The following is a description of a gene set: Human Gene Set: HP_CALVARIAL_OSTEOSCLEROSIS species: Homo sapiens An increase in bone density affecting the calvaria (roof of the skull). Calvarial osteosclerosis, and this is the list of marker genes: TBCE, LRP5, FAM111A, ANKH, AP1S2, DVL1, KL, TCIRG1